Given this list of marker genes TIPARP (NCBI Gene Id 25976), ABR, STK38L, ATG9A, MARCHF4, COL8A2, ATP9A, WIPF2, NRG2, SLC4A5, STRIP2, SFMBT1, PDPK1, CXCL13, GRB14, BTG1, MORN2, TRIAP1, GRAMD1B, MLLT10, ZFP41, MAPK1IP1L, PPP1CB, GIT1, HAUS5, PPAN-P2RY11, ELAVL4, KRT71, NDFIP1, LBH, CFL2, SLC9A7, FUT6, RNF10, ADGRA1, DESI2, FAM53A, ZNF397, TMED3, DPYSL2, TSHZ2, ASIC2, BOK, KSR2, SCAI, RYBP, ALPK2, ABCG4, MYH9, SOX21 (NCBI Gene Id 23490), FBXO31, ARHGAP10, ONECUT1, ZNF792, THBS1, KDM4A, CYP2C8, FXN, TRIO, QSOX2, TNN, THSD7A, DOP1A, DIPK2B, TEAD3, CLOCK, RAP2A, F13A1 (coagulation factor XIII A chain), TMEM120B, CDIN1, TSHZ1, TMEM178B (transmembrane protein 178B), TMEM250 (NCBI Gene Id 90120), MAGIX, ANGPT2, ADAMTS19, EPB41L3, AREL1, KCND2, PTPRT, here is a description of the gene set: studied in species Homo sapiens from publication Chen Y, Wang X (PMID 31504780) Human Gene Set: MIR3665 Genes predicted to be targets of miRBase v22 microRNA hsa-miR-3665 in miRDB v6.0 with MirTarget v4 prediction scores > 80 (high confidence targets).